Given this list of marker genes JAM3, CD47, MIR146A, CCR2, AGER, PDGFD, PLCB1, here is a description of the gene set: Any process that modulates the frequency, rate or extent of monocyte extravasation. Human Gene Set: GOBP_REGULATION_OF_MONOCYTE_EXTRAVASATION studied in species Homo sapiens